The following is a description of a gene set: With increasing age, the ability of the immune system to protect against recurring infections or to control chronic infections erodes. The objective of the current study was to identify gene expression signatures in elderly CD4 T cell responses Human Gene Set: GSE36476_CTRL_VS_TSST_ACT_72H_MEMORY_CD4_TCELL_OLD_DN Genes down-regulated in comparison of untreated CD4 memory T cells from old donors versus those treated with TSST at 72 h. species: Homo sapiens from publication Yu M, Li G, Lee WW, Yuan M, Cui D, Weyand CM, Goronzy JJ (PMID 22434910), and this is the list of marker genes: MRPL15, SEPHS2, GMPPB, SPAG5, RBM4B, JPT2, GSTO1, GNPDA1, TRIM32, CCT3, GSDME, EGR3, SNRNP25, MTCH2, PSMD2, KIF11, GLRX2, COL6A3, TEX10, FH, CTPS1, EMC9, PAICS, MKI67, STMN1, CDC20, RAD51C, NUDT1, MTHFD1, TUBB, NIT2, TMEM106C, FOXM1, TUBA1C, CCNA2, UBE2C, NCAPG, HAUS4, NUP93, KIF23, TP53BP1, DHRS7B, ALAS1, TPI1, CDCA3, KIF4A, MCM5, PLK4, GBP2, CSTF2, KIF20A, CLCC1, GART (NCBI Gene Id 2618), GATB, TARS1, NUSAP1, FANCI, MCM10, IL1R1, OIP5, SNX1, CDK2AP1, LAMP3, IL2RA, TUBG1, CCNB1, AURKA, MMUT, PCLAF, SNUPN, FANCE, ZBED2, TIMELESS, LXN, TK1, MFSD5, ASPM, FUCA1, APOL1, SMARCAL1, PGAM1, MIS18A, FOCAD, GOT1, CTSH, CORO1C, NCAPG2, TOP2A, SHMT1, HMGN2, CEP76 (NCBI Gene Id 79959), TUBB2B, MCM7, RIDA, SLCO4A1, ZNF189, NCAPH, LYRM4, COMMD4, VDR, MYOF, TIMM8B, MRPL18, HMGB3, PCCB, RFC4, GLA, LIMA1, ACOT13, CKAP5, DTL, MELK, RNASEH2A, UNG, HJURP, SRSF1, ZWINT, PSMB2, MYB, TPX2, ICMT, NCBP1, MRPS14, DLGAP5, TMPO, HMMR, IRF4, RAD51, SLC47A1, NAP1L4, MCM2, WARS1, MCM4, GTDC1, BLM, JPT1, ATF6, CKS1B, HNRNPAB, RBBP8, MLYCD, CENPF, KEAP1, CYC1, POLD3, FADD, CDC6, GOT2, SMC2, SMCO4, PSMB5, NDUFA6, FANCG, EBNA1BP2, BUB1B, NME1, SUCLG1, RACGAP1, NEDD4, CCT4, CENPU, ACTG1, POLE2, CCNE1, GLB1, RAD51D, GTF2H4 (general transcription factor IIH subunit 4), DPP3 (NCBI Gene Id 10072), IARS1, MED8, RRM2, TYMS, CDK4, CLTC, GINS2, CEP55, CENPM, ACOT7, FEN1, RAB33A, FAH, UCK2, MACROH2A1, MYL6B, MRPL11, BDH1, PSMG1, ZWILCH, SLC43A3, FAM50B, TRIP13, ESPL1, AARS1, NDUFS2, TUBA1B, CCNB2, CENPA, METTL5, AURKB, CCDC51